The following is a description of a gene set: Any process that results in a change in state or activity of a cell (in terms of movement, secretion, enzyme production, gene expression, etc.) as a result of a salt stimulus. studied in species Mus musculus Mouse Gene Set: GOBP_CELLULAR_RESPONSE_TO_SALT, and this is the list of marker genes: Grp, Hsf1, Atg7, Zc3h12a, Hnrnpa1, Daxx, Enpp1 (NCBI Gene Id 97628), Mapk13